Given this list of marker genes FABP5, SNHG12, UNC5D, SPRY2, ATXN2, FBXW9, PPP4R3C, HAUS3, BTBD3 (BTB domain containing 3), KLHDC8A, YBX3, GYPE, MDN1, EDEM1, GANC, PDE4B, CAPN12, ST8SIA1 (ST8 alpha-N-acetyl-neuraminide alpha-2,8-sialyltransferase 1), IGFBP4, FGF7P3, NELL2, ENSG00000261327, SEMG1, TGFBI, TNFAIP8L1, SYNE3, GABRB1, NCAN, TMEM143, RASSF2, FBXO45, ZBTB20, SCML4, ADGRF2P, AHR, RGMB, RHOU, FBXL16, CD28, HK2, PLEKHA5, OR11A1, RD3, RASSF7, MZF1-AS1, BBIP1, IL6R, HLA-DMA, TCF7, TUBG1, CCDC141, PRDM8, MS4A1, PER2, EIF3J, RCAN3, ENKD1, LRRC8B, SCARNA2, MPP4, LEF1, LL22NC03-63E9.3, FCGRT, TMEM14B, REG1B, HMGB3, ASAP1, TNFSF8, LTB, TAS1R1, ANTKMT, BEX1, CCR5, CARD19, SIRPG, SPSB1, GREM2, TUBA4B (tubulin alpha 4b), MPI, CDCA7, SF1, CYSLTR2, CYB561, LSR, KIF3B, CLU, MTHFD1L, CXCR6, AKIRIN1, TRABD2A, ATP11C, MICU3, ZEB1, SMAP2, FBXO41, ZNF587, B4GALT2, ADAMTSL4, MID1IP1, CHRNA5, CAMK4 (calcium/calmodulin dependent protein kinase IV), ADGRE1, TBC1D4, RPL35, HIVEP2, TCEAL2, AXIN2, LINC00641, PIK3R1, PWWP3B, VSIG1, KCNN3, EOLA1-DT, PRICKLE2, UBASH3A (ubiquitin associated and SH3 domain containing A), GPER1, COL12A1, DENND5A, LEFTY1, CEP68, LIMK2, MAL, ITGA6, SNN, MYC, CASP6, CLUAP1, CPNE2, DUSP4, LEPROTL1, RAB3GAP1 (RAB3 GTPase activating protein catalytic subunit 1), TMEM91, HMGA1, STK33, LINC02520, GZMK, BEX3, HELB, PVT1, TTLL4, RASGRP3, DKK3, MBOAT1, CTC1, PLA2G4C, IL12A (interleukin 12A), MCUB, ABCB5, C11orf87, ZNF416, CAPG, RPS16P5, DTX1, TTN (NCBI Gene Id 7847), SNHG16, TOMM22, SHISA3, HSBP1L1, RASGRF2, IFI44L, KCNK5, ECRG4 (NCBI Gene Id 84417), FCRL2, SNX30, CETP, BTLA, TNFRSF10B, A1BG, MRPL4, AGO2 (NCBI Gene Id 286109), GATA3, SPECC1, TMEM14C, TRAF1, USP6NL, TRAT1, CLPP, ATG16L1, RYR1, CLIC5, PUS7, TAB2, GADD45A, SPRY1, SOX1, IL21R-AS1, NCLN, KCNA3, NFKB1, EEIG1, GPR183, here is a description of the gene set: Human Gene Set: GSE21063_CTRL_VS_ANTI_IGM_STIM_BCELL_3H_UP Genes up-regulated in B lymphocytes: control versus stimulated by anti-IgM for 3h. Triggering of B cell receptors (BCR) induces a massive synthesis of NFATc1 in splenic B cells. By inactivating the Nfatc1 gene and re-expressing NFATc1 we show that NFATc1 levels are critical for the survival of splenic B cells upon BCR stimulation. NFATc1 ablation led to decreased BCR-induced Ca++ flux and proliferation of splenic B cells, increased apoptosis and suppressed germinal centre formation and immunoglobulin class switch by T cell-independent antigens. By controlling IL-10 synthesis in B cells, NFATc1 supported the proliferation and IL-2 synthesis of T cells in vitro and appeared to contribute to the mild clinical course of Experimental Autoimmune Encephalomyelitis in mice bearing NFATc1-/- B cells. These data indicate NFATc1 as a key factor controlling B cell function. species: Homo sapiens from publication Bhattacharyya S, Deb J, Patra AK, Thuy Pham DA, Chen W, Vaeth M, Berberich-Siebelt F, Klein-Hessling S, Lamperti ED, Reifenberg K, Jellusova J, Schweizer A, Nitschke L, Leich E, Rosenwald A, Brunner C, Engelmann S, Bommhardt U, Avots A, Müller MR, Kondo E, Serfling E (PMID 21464221)